The following is a description of a gene set: Neighborhood of DFFA Neighborhood of DFFA DNA fragmentation factor, 45kDa, alpha polypeptide in the GCM expression compendium species: Homo sapiens Human Gene Set: GCM_DFFA, and this is the list of marker genes: CTDNEP1, BOD1L1, RBM17, TAF9B, ISCA1, CLK4, SNRNP200, ACTR6, EPM2AIP1, CIZ1, RABGEF1, RMDN3, SMAD2, MTMR1, RTCA, KLHL42, MARCHF6, WDR70, IPO9, TBC1D10B, VPS52, C2CD3, NFYA, MARF1, MED17 (NCBI Gene Id 9440), HECTD3, CNOT7, C1orf52, NAB1, KAT7, LARS1, SCARB2, MEPCE, SMC3, BRPF3, POGZ, REPS1, CAND1, DFFA, UBR7, ZNF529, FAM8A1, ZFP62, EXOC5, NAA30, MEX3C, RBM8A, ZNF384, ZBTB33, YME1L1, ZBED1, PA2G4, KANK2, HNRNPU (heterogeneous nuclear ribonucleoprotein U), CHTOP, ARMC8, VEZF1, ERG28, KHDC4, LEMD3, NUP133, LINC01278, FBXO30, ARID1A, NGRN, HNRNPH3, CSDE1, RBPJ, TOMM70, CELF1, RBM25, ARL5A, ELP1, EPC2, SLC25A33, NAA25, PRKRA, TRAPPC6B, TUBGCP3, RAN, USP33, PHF2, ZNF512, SLC25A29, PFAS, ASB3, RPL7L1, KMT2A, DHX36, PDCL, CEP76 (NCBI Gene Id 79959), TARDBP, CS, RALGAPA1, FAM168B, OGFOD1, IPO5, ARID4B, CRNKL1, ZNF655, RMND5A, GTPBP1, DMTF1, CCDC82, SPAST, BCL2L1, SMG1 (SMG1 nonsense mediated mRNA decay associated PI3K related kinase), UBA2, C2CD5, KDM3B, ZMYM2, NCOA5, HECTD1, ZFAND5, TCERG1, ANKRD17, HEATR5B, PRPF8, PPM1B, BTRC, USP19, FBRSL1, HNRNPR, COMMD9, PRRC2B, DYNC1I2, UFSP2, KPNA3, BAZ2A